Given this list of marker genes Cox10, Pgrmc1, Fxn, Tmem14a, Abcb7, Uros, Ireb2, Cox15, Hnf1a, Snx3, Hmbs, Urod, Alad, Srrd, Slc11a2, Fech, Slc6a9, Alas1, Alas2, Iba57, Ppox, Slc25a39, Cpox, Tmem14c (transmembrane protein 14C), Atp5if1, Abcb10, here is a description of the gene set: The chemical reactions and pathways resulting in the formation of heme, any compound of iron complexed in a porphyrin (tetrapyrrole) ring, from less complex precursors. species: Mus musculus Mouse Gene Set: GOBP_HEME_BIOSYNTHETIC_PROCESS